The following is a description of a gene set: from publication Chen Y, Wang X (PMID 31504780) Genes predicted to be targets of miRBase v22 microRNA hsa-miR-1243 in miRDB v6.0 with MirTarget v4 prediction scores > 80 (high confidence targets). species: Homo sapiens Human Gene Set: MIR1243, and this is the list of marker genes: ATAD1, TBL1XR1, STXBP5, AGK, THAP6, ECT2L, GOLGA6L6, SSPN, ZNF649, MAP3K5, RAD21, C10orf88, GNPDA1, SALL1, RMI1, GOLGA6L1, ARHGAP31, ZNF608, PALD1, ASXL3, DNAJC6, TRIM4, CA1, TENT4B, HNRNPH2, CALCB, YME1L1, TMEM30A, RAP1B, ANKRD63, PLEKHA5, SUZ12, HOXD10, TAGAP, MYOZ1, WDR77, TEDDM1, ASB7, RPL36A-HNRNPH2, SGIP1 (NCBI Gene Id 84251), OSBPL11, ZNF382, CLUL1, HACD2, GUCA1C, ZNF561, MBL2, TLR4, PRKG2, ERC2, STC2, TPP2, FRRS1L, AEBP2, AMFR, H2BC18, TSTD2, TNS3, SLC11A2, ZC3H4, CEP72, PTPN11, TMEM267